Given this list of marker genes PALS1, F2RL2, AHCYL2 (adenosylhomocysteinase like 2), CABP5, ECSIT, THUMPD1 (THUMP domain containing 1), DHRS3, XCR1, ERBIN, FPR3, FCGR3A, MS4A7, MYH14, SMC3, COL11A2, SNX20, MYOC, MS4A2, CHM, CELA1, POLE3, TOR1AIP2, PORCN, RBMS2, ADIG, MYOZ3, FBXW12, BTG1, PLA1A, PTRH2, SUOX, NRIP3, KIF18A, ANKRD46, FGFRL1, NEK8, ARL6IP1, SH3GL2, VIL1, PRKD1, IQGAP2, PRSS35, RAB1A, CPLX4, ZNF146, ZYG11A, ZBP1, FAM20B, STAT5A, TMEM165, CRMP1, SPP1 (NCBI Gene Id 6696), MCFD2, RAB3B, CRIP1, CBX6, TUSC3, SDHAF2, MYF5, DOLPP1, DOK4, SPMIP10, SF1, AIF1, TSPAN5, CMKLR1, SEC62, PRR13, NCBP3, CAMSAP1, MPEG1, HPD, MDFIC, HOXB1 (NCBI Gene Id 3211), RHOBTB2, HAUS4, MAL2, CBY2, THBS3, LAMP2, CHRNA5, DLX1 (distal-less homeobox 1), B4GALNT2, BCL11B, AMMECR1, SEPTIN2, RHPN2, ULK1, LEP, CDC25C, RBM3, LAMTOR4, EMC9, IFI27L2, COQ8B (NCBI Gene Id 79934), CSMD1, NFXL1, FBXO15, ZNF565, PPP6R3, GJB3, MRPL11, KCNK13, AKAP1, PNPO (pyridoxamine 5'-phosphate oxidase), FOXA2, FMO4, TLR6, USP17L2, IFIT2, SEC22B, IQCC, SEC22A, TPD52, CPA5, MPC1, DGCR8, TMUB1, U2SURP, PDCD6, STAM2, RPL11, SNX10, TMEM45B, KLHL11, ICAM5, OR5D18, PLCB4, GRIN3B, BCAS2, PRCP, LYRM1, DCAF8, ZIM3, YWHAZ, PSENEN, COL4A6, ASAH1, ATF7IP2, MYL4, CUTA, CASR, GLYAT, CTSB, LYSMD3, C18orf32, CHRNB4, SPPL2A, RCOR3, PHF7, RWDD2B, CCL17, PSMB1, GZMK, GFRA3, TGFBR1, CCDC82, SLC22A12, TSPAN4, ELK1, SYNPR, OR13J1, EXTL2, KRT34, AXIN1, AHCYL1, ARL2, CARD14, ENG, C5orf24, IRAG1, ZNF7, HSPA1L, HELQ, YJU2B, NMUR1, SCML4, RPS6KA3, GBP6, RBM39, MLXIPL, SLC15A3, DOC2B, TMEM106B, OSCAR, FASTKD5, NHSL2, IFT22, GPRC5B, DNAJB6, TIMP4, TBATA, HEMK1, SENP3, FAM83F, ACP5, SOX5, CLEC7A, COPS5, PGAM1, here is a description of the gene set: species: Homo sapiens from publication Amit I, Garber M, Chevrier N, Leite AP, Donner Y, Eisenhaure T, Guttman M, Grenier JK, Li W, Zuk O, Schubert LA, Birditt B, Shay T, Goren A, Zhang X, Smith Z, Deering R, McDonald RC, Cabili M, Bernstein BE, Rinn JL, Meissner A, Root DE, Hacohen N, Regev A (PMID 19729616) mouse primary BMDCs were stimulated with tlr ligands and gene expression changes were profiled on Affymetrix arrays Genes down-regulated in comparison of dendritic cells (DC) stimulated with LPS (TLR4 agonist) at 0.5 h versus DC cells stimulated with CpG DNA (TLR9 agonist) at 0.5 h. Human Gene Set: GSE17721_LPS_VS_CPG_0.5H_BMDC_DN